Given this list of marker genes Aqp1, Pkd1, Slc22a1, Acat1, Slc22a6, here is a description of the gene set: The process whose specific outcome is the progression of the metanephric proximal tubule over time, from its formation to the mature structure. The metanephric proximal tubule is a metanephric nephron tubule that connects Bowman's capsule to the descending thin limb of the loop of Henle in the metanephros. It has a brush border epithelial morphology. Mouse Gene Set: GOBP_METANEPHRIC_PROXIMAL_TUBULE_DEVELOPMENT studied in species Mus musculus